The following is a description of a gene set: Mouse Gene Set: GOBP_REGULATION_OF_NUCLEOBASE_CONTAINING_COMPOUND_TRANSPORT species: Mus musculus Any process that modulates the frequency, rate or extent of the directed movement of nucleobases, nucleosides, nucleotides and nucleic acids, into, out of or within a cell, or between cells, by means of some agent such as a transporter or pore., and this is the list of marker genes: Khdrbs1, Setd2, Nsun2, Wnk1, Nrde2, Ncbp2, Cpsf6, Akap8l (A kinase anchor protein 8-like), Adora1, Supt6, Nup153, Thoc5, Iws1, Dhx9 (NCBI Gene Id 98320), Tpr, Thoc2, Ddx39a, Ripk1, Alkbh5